The following is a description of a gene set: Mouse Gene Set: GOMF_UNFOLDED_PROTEIN_BINDING species: Mus musculus Binding to an unfolded protein., and this is the list of marker genes: Calr3, Hspb2, Nudc, Ptges3, Syvn1, Mkks (NCBI Gene Id 99133), Nudcd3, Cryab, Hspb6, Ern2, Cryaa, Npm1, Erlec1, Cct8, Grpel2, Dnajb6, Naca, Uggt2, Uggt1, Nacad, Hspa2, Pfdn4, Calr, Hspe1-rs1, Dnaja3, Dnajb4, Hspa5 (NCBI Gene Id 99198), Hsp90aa1, Dnaja1, Ptges3-ps, Cct5, Tbce, Cct7, St13, Serpinh1, Dnajb1, Dnajb3, Ccdc115, Hspa9, Ern1, Trap1, Pfdn5, Scg5, Cct3, Hspe1, Cct6a, Shq1, Ndufaf1, Cct4, Dnajb2, Dnajb8, Hspa1b, Canx, Dnaja4, Clu, Pfdn2, Cct2, Hspa8 (heat shock protein 8), Dnajb11, Cct6b, Vbp1, Clpx, Cdc37, Heatr3, Tcp1, Hspa1a, Dnajb13 (NCBI Gene Id 69387), Pdrg1, Hspa1l, Ube4b, Pfdn6, Hspb1, Clgn, Cdc37l1 (NCBI Gene Id 67072), Hsp90ab1, Dnaja2, Dnajb5, Aip, Srsf10, Cct8l1, Grpel1, Dnajb7, Nudcd2, Pet100, Tmem67, Tomm20, Hsp90b1, Pfdn1, Ssu2